The following is a description of a gene set: species: Homo sapiens Human Gene Set: GOBP_REGULATION_OF_HEART_RATE_BY_CHEMICAL_SIGNAL The regulation of the rate of heart contraction mediated by chemical signaling, hormonal, autocrine or paracrine., and this is the list of marker genes: KCNH2, MIR133A1, YWHAE, TPM1, SREBF1, NOS1AP